Given this list of marker genes IGF1, PSEN1, TREM2, TMED10, GSAP, GGA3, RELA, IFNG, TNF, APH1A, BACE2, APH1B, ACE, BACE1, MIR29C, PRNP, MIR206, MIR298, LRRTM3, HAP1, RTN2, MIR339, RTN1, MIR29B1, CLU, DYRK1A, APOE, PSEN2, MIR16-1, ABCG1, SPON1, ABCA7, ABCA2, RTN3, IDE, PSENEN, MIR361, LDLR, ROCK2, MIR15B, CASP3, PICALM, MIR455, NTRK2, LRP4, EPHA4, PIN1, MIR15A, RTN4, MIR186, MIR24-1, MME, REN, CHRNA7, NAT8B, CSNK1E, APEH, SP1, MGAT3, MIR29A, BIN1 (NCBI Gene Id 274), MIR103A1, MIR153-1, LRP1, APOA1, SLC2A13, GSK3A, SORL1, CD36, BECN1 (beclin 1), IFNGR1, EFNA1, NCSTN, ROCK1, here is a description of the gene set: studied in species Homo sapiens Human Gene Set: GOBP_AMYLOID_BETA_METABOLIC_PROCESS The chemical reactions and pathways involving amyloid-beta, a glycoprotein associated with Alzheimer's disease, and its precursor, amyloid precursor protein (APP).